Given this list of marker genes MATR3, TNNT1, RRM2B, CFL2, ERBB4, LRP12, MPZ, NF2 (NCBI Gene Id 654093), RAB7A (NCBI Gene Id 7879), TRPV4, CRYAB, GDAP1, TBCE, TIA1, TTN, MTRFR, ALDH18A1, NEFH, COL6A2, CCNF, MYOT, NEK1, OPTN, HINT1, ATP1A1, PON3, FLNC, SBF2, MORC2, FA2H, SPTLC2, GIPC1, DES, SH3TC2, DNAJB2 (DnaJ heat shock protein family (Hsp40) member B2), VWA1, KLHL41, BSCL2, SCO2, PTRHD1, ANG, SLC25A21, KIF1A, TPM3, GJB1, PRX, FIG4, SPTAN1, COL12A1, TAF15, MPV17, SYT2, IGHMBP2, SOD1, COL6A1, NOTCH2NLC, COX6A1, CHMP2B, CHCHD10, DUX4, ATL3, PPARGC1A, ACTN2, GLE1, FRG1, SPG11, JAG1, FUS, MYH7, PON1, ADSS1, RTN2, AARS1, LYST, ATL1, TARDBP, SPTLC1 (serine palmitoyltransferase long chain base subunit 1), SELENON, HACD1, ACTA1, GNE, KARS1, UNC13A, LRSAM1, DUX4L1, HSPB1, LIG3, GNB2, LMNA, MYL2 (NCBI Gene Id 4633), FHL1, COX20, INF2, TCAP, SIGMAR1, MME, KIF1B, SMCHD1, TREM2, RAI1, MCM3AP, CADM3, UBQLN2, SLC12A6, EGR2, ATXN2, RILPL1, ITGA7, GYG1, PNPLA2, MARS1, DAO, DNMT3B, PFN1, MFN2, NEB (nebulin), TYMP, ANXA11, HNRNPA1, PRPH, PON2, PMP22, DYSF, ORAI1, VCP, VAPB, SACS, LBR, CFAP410, LDB3, NEFL (neurofilament light chain), COL6A3, SQSTM1, REEP1, TPM2, MAP3K20, KY, TBK1, COA7, GBF1, PLIN4, LMOD3, POLG, DCTN1, GLT8D1, here is a description of the gene set: species: Homo sapiens Foot dorsiflexor weakness Weakness of the muscles responsible for dorsiflexion of the foot, that is, of the movement of the toes towards the shin. The foot dorsiflexors include the tibialis anterior, the extensor hallucis longus, the extensor digitorum longus, and the peroneus tertius muscles. Human Gene Set: HP_FOOT_DORSIFLEXOR_WEAKNESS